The following is a description of a gene set: species: Mus musculus This event has been computationally inferred from an event that has been demonstrated in another species.<p>The inference is based on the homology mapping from PANTHER. Briefly, reactions for which all involved PhysicalEntities (in input, output and catalyst) have a mapped orthologue/paralogue (for complexes at least 75% of components must have a mapping) are inferred to the other species. part of: Antigen processing-Cross presentation Reactome Pathway: Cross-presentation of particulate exogenous antigens (phagosomes) electronically inferred by orthology from the curated human pathway, and this is the list of marker genes: Cyba, Ncf1, Cd36, Ncf2, Itgb5